Given this list of marker genes IHH, GNPTG, VPS33A, GLB1, BGN, PHEX, RAB23, GPC3, AIFM1, CREBBP, FLNA, EP300, MMP13, ARSB, TRPV4, GPX4, GPC4, B3GALT6, IDUA, GNPTAB, TRIP11, DDR2, here is a description of the gene set: Flared iliac wing Widening of the ilium ala, that is of the wing of the ilium, combined with external rotation, leading to a flared appearance of the iliac wing. Human Gene Set: HP_FLARED_ILIAC_WING species: Homo sapiens